The following is a description of a gene set: Genes encoding proteoglycans One hallmark of ECM proteins is their domain-based structure. Exploiting this characteristic, we established a list of diagnostic InterPro domains commonly found in ECM proteins. We know that some of the domains used to select positively for ECM proteins are also found in transmembrane receptors and proteins involved in cell adhesion (growth factor receptors, integrins, etc) that do not belong to the ECM. These families of proteins also display a subset of specific domains and transmembrane domains incompatible with definition as from publication Naba A, Clauser KR, Hoersch S, Liu H, Carr SA, Hynes RO (PMID 22159717) Mouse Gene Set: NABA_PROTEOGLYCANS species: Mus musculus, and this is the list of marker genes: Dcn, Omd, Prg3, Prg2, Esm1, Chad, Spock3, Optc, Nyx, Lum, Spock1 (sparc/osteonectin, cwcv and kazal-like domains proteoglycan 1), Bgn, Nepn (NCBI Gene Id 66650), Podnl1, Hapln2, Acan, Bcan, Hapln1, Prelp, Spock2, Aspn, Ncan, Epyc, Hapln4, Impg2, Impg1, Hspg2, Vcan, Hapln3, Ogn (osteoglycin), Prg4, Srgn, Fmod, Podn, Kera, Chadl